Given this list of marker genes ZNF140, LRRC49, SH2B3, MICALL2, RFPL3S, USP11, HOXA1, MCOLN1, GNL1, PPME1 (NCBI Gene Id 51400), SATB2, DLEU2, FASTKD2, CNTRL, FAM83E, RHOBTB3, TP53BP2, SFTPA2, PHF2, CUX1, RAPGEF6, ECD, AKAP8, TRIM21, ETNK1, DCP1A, TBXAS1, CFLAR, TUG1, CMC2, AFF4, BTG2, TFG, TNFRSF4, TNNC2, IRF4, AUTS2 (activator of transcription and developmental regulator AUTS2), SAMD9, LGALS8, GHITM, ACTL8, USP9X, TOR1B, PKNOX2, DCTN5, EPHB4, USP16, SUPT6H, EML4, HSPA9, AFTPH, ZNF143, NEBL, DUOX2, PRKCI, SYP, CTBP2, JUNB (JunB proto-oncogene, AP-1 transcription factor subunit), CTNNA1, GNG5, GRIN1, RAB2A, SF1, IFIH1 (interferon induced with helicase C domain 1), SEMA6A, CAPN2, ZNF189, CCL5, OFD1, NOTCH1, G3BP2, GALNT6, AGFG1, CFB, EPS8L1, PCDHB1, NFKB1, PCNT, UBE2W, TOPORS, RGS17, CHMP6, SMURF2, NKAIN1, CSNK1G1, RB1CC1, MYH9, ARAP3, MUC1, MAD1L1, SH3BP5, LRRFIP2, CD68, PPFIA2, KRT83, KIF25, IL13RA2, CTBS, SLC25A32, C5AR1, RAB1A, AFDN-DT, TET3, RAPGEF1, HAT1, FFAR3, CMKLR1, LEPROT, EOLA2, STAT3, MDM2, BMAL2, GATA4, SEC23B, TSPYL1, KRT85, SOX13, AIM2, GATA6 (GATA binding protein 6), MAMLD1, PLSCR2, SLC3A2, CDV3, KCNC4, RUBCN, RAB22A, KCNK10, CTTN, NPC1, GDAP1, SNED1, PDLIM3, REN, PFKFB3, AMMECR1, RHOH (ras homolog family member H), TSPOAP1, UBE3A, ZNF202, RHEB, COBL, BTG3, ITGB1, SERPINB1, SRSF5, BCL2L11, GALNS, ST3GAL5, NR3C1, TPM4, IER5, PHF14, TASOR, TMEM87A, NOL3, REPS2, ANKRD7, PPFIBP1, SOD3, AKAP12, CASS4, PRR16, BEX1, CTSV, TM4SF1, KIAA0753, DNTTIP2, TMEM43, PPIF, NRP2, RNF10, UBE2Z, GALNT12, AP2B1, LONP2, ATN1, PSG7, HPGD, SEMA3F (NCBI Gene Id 7868, semaphorin 3F), LMTK2, SNRK, LITAF, EIF4E, CTSH, PPP1R10, DHCR7, APLP2, CEP135, CST7, FBRS (fibrosin), RTF2, STK38L, TNFRSF1B, CHRD, RAB8B, EIF6, GPR52, here is a description of the gene set: In order to identify the molecular mechanisms of PPARgamma phosphorylation at Set273, we generated cell-lines of PPARgamma KO MEFs expressing wtPPARgamma or S273APPARgamma. In addition, because our data showed that PPARgamma ligand drugs such as rosiglitazone and MRL24 blocked this phopshorylation, we treated cells with these drugs, then prepared RNA samples to look at the gene profiling. from publication Choi JH, Banks AS, Estall JL, Kajimura S, Boström P, Laznik D, Ruas JL, Chalmers MJ, Kamenecka TM, Blüher M, Griffin PR, Spiegelman BM (PMID 20651683) Human Gene Set: GSE22033_UNTREATED_VS_MRL24_TREATED_MEF_DN species: Homo sapiens Genes down-regulated in mouse embryonic fibroblasts (MEF): untreated versus MRL24.